The following is a description of a gene set: studied in species Homo sapiens Human Gene Set: WP_CHOLESTEROL_SYNTHESIS_DISORDERS Cholesterol synthesis disorders, and this is the list of marker genes: IDI1, FDPS, PMVK, MVK, FDFT1 (farnesyl-diphosphate farnesyltransferase 1), DHCR24, MVD, DHCR7, CYP51A1, LSS, HSD3B2, EBP, SC5D, MSMO1, HMGCS1, LBR, SQLE, HMGCR